The following is a description of a gene set: The process in which the branching structure of the prostate gland is generated and organized. A branch is a division or offshoot from a main stem. Mouse Gene Set: GOBP_BRANCHING_INVOLVED_IN_PROSTATE_GLAND_MORPHOGENESIS studied in species Mus musculus, and this is the list of marker genes: Bmp7, Fgfr2, Hoxd13, Hoxa13, Rxra, Nkx3-1, Frs2, Fem1b, Esr1, Hoxb13, Sfrp1, Igf1, Bmp4, Shh, Cd44